The following is a description of a gene set: Phospholipase C-gamma (PLC-gamma) is a substrate of the fibroblast growth factor receptor (FGFR) and other receptors with tyrosine kinase activity. It is known that the src homology region 2 (SH2 domain) of PLC-gamma and of other signaling molecules (such as GTPase-activating protein and phosphatidylinositol 3-kinase-associated p85) direct their binding toward autophosphorylated tyrosine residues of the FGFR. Recruitment of PLC-gamma results in its phosphorylation and activation by the receptor. Activated PLC-gamma hydrolyzes phosphatidyl inositol P2 to form the second messengers diacylglycerol (DAG) and InsP3, which stimulate calcium release and activation of calcium/calmodulin dependent kinases.<br> part of: Downstream signaling of activated FGFR4 studied in species Homo sapiens Reactome Pathway: Phospholipase C-mediated cascade; FGFR4, and this is the list of marker genes: FGF9, FGF20, FGF16, FGF8, FGF2, FGF18, FGF23, KLB, FGF1, FGF4, FGFR4, FGF19, FGF6, FGF17, PLCG1